The following is a description of a gene set: Germ cell neoplasia Human Gene Set: HP_GERM_CELL_NEOPLASIA studied in species Homo sapiens, and this is the list of marker genes: CDKN2A, NR0B1, ZFPM2, CDKN1C, NR5A1, KIT, CHEK2, PAX6, PRKAR1A, MDM2, STK11, CDH1, GATA4, CTNNB1, WWOX, PIK3CA, NSD1, KCNQ1, SRY, AR, IGF2, FGFR3, DICER1, FGFR2, MNX1, DHH, KCNQ1OT1, KEAP1, SOX9, STS, MSH3, BCL10, ERBB2, APC2, AKT1, OPCML (NCBI Gene Id 4978), SETBP1, WT1, PDE11A (phosphodiesterase 11A), RNF43, PRKN, DHX37, TP53, VAMP7, MAP3K1